Given this list of marker genes Eda2r (NCBI Gene Id 279598), Mras, Fbxw11, Pank3, Kif3b, Specc1, Zfp704, Cenpb, Ugt2a2, Zfp994, Cep97, Nudt3, Tnf, Ppara, Hoxc10, Fubp3, Naa15, Spta1, Heatr6, Pigh, Kcnn4 (potassium intermediate/small conductance calcium-activated channel, subfamily N, member 4), Mbnl1, Ccdc121rt1, Rpgr, 9330159F19Rik, Slc43a2 (solute carrier family 43, member 2), Acsl1 (acyl-CoA synthetase long-chain family member 1), Nudt12, Tnrc6b, Rasef, Zfp119a, Zfp933, Aak1, Cnot6l, Tmprss13, Polr1h, Il1rap (NCBI Gene Id 319228), Sema3e, Gfpt2, Slco1a1 (solute carrier organic anion transporter family, member 1a1), Map3k20, Cep70, Lpgat1, Mprip, Slain2, Cacna1g, Ctsk, Map1b, Ppm1e, Lix1, Cdh3, Dio2, Ccng2, Slc38a2, Plpp1, Sorcs2, Chrdl1, Ralgapb, Mcf2, Znrf3, Zfp882 (zinc finger protein 882), Aldh6a1, Nsg1, Thoc2, Slc8a1, Tceanc2, Tgfb3, Trip4, Psme3ip1, Sspn, Bcl6, Birc3, Dnajc5b, Stk39, Sting1, Dclk1, Lhx9, Gabpb1, Slc7a6, Ikzf2, Ap2a2, Itga9, Zfp808, Ak2, Nexmif, Gm3604, Bcat1, Zbtb43, Capn5, Cept1, Hsd17b1, Poldip3, Acvr2b, Rhof, Stard3nl, Nfasc, Icmt, Chic1, Klhdc8a, Fbxo30, Zfhx3, Tmem154, Dmac2l, Poc5, Vps37c, Fbrsl1, Enpp6, Gadd45a, Mybl1, Pcyt1a, Entpd7, Fmnl3, Dlgap1, Tepsin, Gbp8, Trak2, Zkscan8, Snx4, Gjc3, Nfe2l1 (nuclear factor, erythroid derived 2,-like 1), Atp6v1g3, Tmem80, Baiap2l1, Lrig2, Klf9, Taf2, Npr3, Dusp16, Tollip, Pmel (NCBI Gene Id 20431), Prdm16, Cstpp1, Celf3, Ppm1l, Sp1, Aqp4, Gatc, Mta2, Arl6ip1, Asxl2, Tln2, Tenm3, Lsm1, Lrrc7, Scn8a, Serpinb7, Slc6a1, Cstf2, Cds2, Dpy30, Abtb3, Hlcs, Tmem45b, Nipal1, Zfr, Iho1, Tmigd1, Rem1, Ugt2a1, Nfat5, Gria3, Fam204a, Srpra, Klhl20, Tlnrd1, Ebag9, AU041133, Pax3, Msl3, Trib1, Prkar2a, Hlf, Spdya (speedy/RINGO cell cycle regulator family, member A), Col11a1, Fzd3, Klhl15, Hdx, Cycs, Dicer1, Camk4, Tspan2, Frat2, Fbxl5, Camsap1, Fgf14, Slc25a16, Ccdc74a, Glcci1, Aff1, Slc38a7 (solute carrier family 38, member 7), Zftraf1 (NCBI Gene Id 54151), Slc22a30, Psd3, 4930571K23Rik, Dusp22, Cacna2d4, Rbm20, Plscr2, Epb41, Arf1, Gcnt4 (NCBI Gene Id 238786), Ptger2, Enpp4, Naaladl2, Slc12a8, Azin1, Atg4b, Dlgap2, Wasf1, Fut9, Nbea, Itga8, Maml1, Amotl1, Togaram1, Pbx2, Zfp958, Ptpdc1, Lce1d, Ncs1, Mtcl1, Mapk14, Wnk4, Eipr1, Sgsm2, Tia1, Mreg (melanoregulin), Mtmr14 (myotubularin related protein 14), here is a description of the gene set: Mouse Gene Set: MIR_7026_5P studied in species Mus musculus from publication Chen Y, Wang X (PMID 31504780) Genes predicted to be targets of miRBase v22 microRNA mmu_miR_7026_5p in miRDB v6.0 with MirTarget v4 prediction scores > 80 (high confidence targets).